Given this list of marker genes Mogat2, Tkfc, Got1, Mogat1, Gpd2, Pck1, Sord, Coq3, Coq2, Galk1, Angptl3, Pgp, Gk2, Gk, Gk5, Gykl1, Fkrp, Pla2g4a, Myof, Akr1b1, Dgat2 (diacylglycerol O-acyltransferase 2), Pck2, Tpi1, Lep, Dysf, here is a description of the gene set: Mouse Gene Set: GOBP_ALDITOL_METABOLIC_PROCESS species: Mus musculus The chemical reactions and pathways involving alditols, any polyhydric alcohol derived from the acyclic form of a monosaccharide by reduction of its aldehyde or keto group to an alcoholic group.